Given this list of marker genes FARSA, MAGOH-DT, PSMD2, ZNF614, CD81, USP16, HSD17B12, FLJ40288, PRDX4, KLF10, HMGCS1, RPIA, CACNA1A, OGFOD1, ECD, ZNF326, ZNF135, PHF6, ALCAM, PKIA, IL4R, C12orf43, EXTL2, PDIA5, HMGB3P30, SF3B5 (NCBI Gene Id 83443), MLF1, ODR4, RAB30, SERPINB13, STAT4, GCNA, ENSG00000269210, PAPPA2, RHOB, PIGW, THOP1, DDX27, ATL2, CHMP4B, NOL6, RTCB, SDHB, RGS16, HS6ST1 (NCBI Gene Id 9394), COX20, NDUFAF3, SELENOT, EIF4A1, C4BPB, PANX1, DNM1L, RC3H1, CTXN1, MIX23, ZNF79, AFG3L2, ANKHD1, HDAC2, IKBIP (NCBI Gene Id 387877), NANP, NFAT5, YIF1A, ADNP2, PYCR1, TP73, PPP4R2, EI24, MRPL32, ABCF3, MFSD14A, PRKDC (NCBI Gene Id 5591), MOCS3, RNPS1, SLX9, CCDC85A, SELENOS, SREBF1, MCAT, TNFAIP3 (TNF alpha induced protein 3), ENO1, IRAK2, PELP1 (NCBI Gene Id 27043), VPS72, PARL, STRAP (serine/threonine kinase receptor associated protein), GCN1, SLC28A2, NFYA, NUP160, NSMF, LMBR1, FCER2, PHACTR1, RUNX3, NUFIP1, NDUFAB1, RRS1, AGFG1, SDAD1, TOP1MT, GPN2, IL17RC, NCL, PDCD11, RLIG1, OR7A5, USP37, MED9, PPM1G, TRMT6, NOL7, YBX1, TMA16, ARL8B, TMEM208, POLR1A, DNTTIP2, RBM17, B4GALT2, MSMO1, FDX1, FAM210A, SLC35B1, CCT6A, S1PR2, SNHG15, SUCO, KCNC2, TTLL4, PTPMT1 (NCBI Gene Id 114971), LAS1L, CKS2, TBX6, MTHFD1L, MIR23AHG (miR-23a/27a/24-2 cluster host gene), SNHG1, GRIN2C, FASTKD5, DPM1, GNL2, MRAP, UBE2E3, SLC17A5, SCML2, HNRNPA1, NOL10, CD226 (NCBI Gene Id 10666), SURF4, CSNK2A1, DDAH1, FUT3 (fucosyltransferase 3 (Lewis blood group), NCBI Gene Id 2525), SHC4, NCS1, TNPO2, TOMM34, RCN1, ZBTB21, TNFRSF1B, ERICH1, NAA25, THRB, FOXN3-AS1, MT1G, TIMM17A, MED19, MPLKIP, RELB, MRPL37, DESI2 (NCBI Gene Id 51029), STX11, SNAPC1, LETM1, MAST2, FAM107B, EIF4H (eukaryotic translation initiation factor 4H), STX6, CAPRIN1, HSPH1, WDR33, DYNLT3, MCOLN2 (NCBI Gene Id 255231), NFIL3, RBM8A, ITPKA, BICDL1, SRSF10, MRPL20, MRPS7, DDX19A, RCC2, HJV, VPS37A (VPS37A subunit of ESCRT-I), KDM5B, CENPV (NCBI Gene Id 201161), SETD9, LINC02875, CXXC1P1, here is a description of the gene set: studied in species Homo sapiens An early-differentiated CD8+ memory T cell subset with stem cell-like properties (TSCM) can be identified within the naïve-like T cell population by the expression of CD95/Fas. Based on experiments including exon- and gene-level expression analysis, we provide evidence that this subset of antigen-specific cells represents an early precursor of conventional central (TCM) and effector (TEM) memory CD8+ T cells with enhanced self-renewal capacity and proliferative potential. We identified genes differentially expressed between major T cell subsets defined along with memory T cell commitment. Based on the analysis of these genes, CD95+ naïve T cells (TSCM) cluster closer to the CD8+ T memory compartment than to classical (CD95-) naïve T (TN) cells, and display an intermittent phenotype between classical TN and TCM cells in terms of all major T cell differentiation markers analyzed. from publication Gattinoni L, Lugli E, Ji Y, Pos Z, Paulos CM, Quigley MF, Almeida JR, Gostick E, Yu Z, Carpenito C, Wang E, Douek DC, Price DA, June CH, Marincola FM, Roederer M, Restifo NP (PMID 21926977) Genes up-regulated in CD8 T cells: stem cell memory versus naïve. Human Gene Set: GSE23321_CD8_STEM_CELL_MEMORY_VS_NAIVE_CD8_TCELL_UP